Given this list of marker genes SLC38A9, RRAGD, LAMTOR2, PRKAG3, STK11, RPTOR, TSC1, TSC2, STRADB, MTOR, PRKAB1, LAMTOR3, PPM1A, PRKAG1, LAMTOR1, LAMTOR5, RRAGA, LAMTOR4, PRKAA1, CAB39, CAB39L, PRKAB2, PRKAA2, STRADA, PRKAG2, RRAGB, RRAGC, MLST8, RHEB, here is a description of the gene set: Human Gene Set: REACTOME_ENERGY_DEPENDENT_REGULATION_OF_MTOR_BY_LKB1_AMPK species: Homo sapiens Energy dependent regulation of mTOR by LKB1-AMPK